Given this list of marker genes LYVE1, LAYN, VCAN, HAPLN1, HAPLN2, ITIH2, CEMIP, TNFAIP6, HAPLN4, NCAN, HAPLN3, BCAN, IMPG2, USP17L6P, IMPG1, SUSD5 (sushi domain containing 5), ACAN (aggrecan), HMMR, STAB1, ITIH1, CHODL, CD44, USP17L24, C1QBP, HYAL2, STAB2, here is a description of the gene set: Human Gene Set: GOMF_HYALURONIC_ACID_BINDING species: Homo sapiens Binding to hyaluronic acid, a polymer composed of repeating dimeric units of glucuronic acid and N-acetyl glucosamine.